The following is a description of a gene set: studied in species Mus musculus Binding to a heavy chain of a myosin complex. Mouse Gene Set: GOMF_MYOSIN_HEAVY_CHAIN_BINDING, and this is the list of marker genes: Calml4, Mybpc3, Nkd2, Myl9, Limch1, Coro1a, Myl12b, Ush1c, Sptbn5, Axl, Pdlim2, Ampd1, Stx1a